Given this list of marker genes CKS2, GREM1, KIF21B, EPC1, ITGA4, USE1, ABHD17C, GCM1, NPTXR, PDLIM5, RAI14, PALS1, ACSL1, DLK2, SPSB4, CRYGD, NOCT, SCAND1 (SCAN domain containing 1), NR1D1, GPR37L1, LTBP3, TRAF1, NFKBIB, KLK8, SRY, TADA3, FBRS, NENF, FHL3, CRK, CTLA4, IL20 (interleukin 20), YIPF3, PLCL2, KCNJ1, IER5, ARHGEF3, IGSF9, ISG15 (NCBI Gene Id 9636), FABP4, RPLP0, NT5C3B, SGCG, MTMR14, MTREX, ZSWIM9, DAPP1, ATF5, ZBTB16, PRNP (prion protein (Kanno blood group)), EVL, SPTAN1, CAPN2, TGM2, AEBP2, GIMAP1, UBE2O, CD7, KRT33B, SLC7A2, FAM133B, PELI2, FABP6, IFT81, SLC44A3, ADM, RGS9, TNFSF9 (TNF superfamily member 9), SNRPB2, KCTD10, PARK7, SDSL, SMARCE1, CDK18 (cyclin dependent kinase 18), SULT1E1, GDAP1L1, GRID2, CCL22, REL, MS4A3, ARG2 (arginase 2), AMMECR1L, PHF13, INAVA, SDF2L1, NIBAN1, OR52A1, TNF, LCP2, RABGEF1, ANXA8 (annexin A8), NTMT1, DDAH2, DEGS2 (delta 4-desaturase, sphingolipid 2), GPBP1, ZNRF1, RSPRY1, LNX2, LTA, CDKN1A, LAMA5 (NCBI Gene Id 3911), ID1, POLD1, RPS27, UQCC2, RAB32, SYN3, SLC3A2, EIF1, PTCH2, KRT5, GPR85 (NCBI Gene Id 54329), GALNT16, FABP3, GADD45B, PRELID1, RTP3, MRPL13, CCT5, KRT85, KIF20A, PPP1R15B, EPHB4 (EPH receptor B4), SLC25A20, P2RY14, PEX7, GRHL1, FGF22, ZNF296, COL9A1, CDK2AP1, HILPDA, ICAM1, GNL3, CNNM3, HAO2, VPREB3, MYBPH, LHX2 (LIM homeobox 2), CDC42EP4, TECTB, ETFDH, ELOC (NCBI Gene Id 6921), THRSP, RFX3, AMPD3, VANGL2, NEK2, GLA, ICOSLG, MYEF2, CA13, MECR, LHX5, BLMH, DUOXA1, EPHA4, HTR3B, NUP62, DTX2, GUCY1A1, SIAH2, ACTRT1, ZNF830, GLRX3, GLRA3, SPIC, RELA, INHA, OPN1SW (NCBI Gene Id 611), PLA2G6, AVP, SATB2, SERPINB5, B3GNT2, MVD, POLA2, DNAJB4, TMEM115, TMEM191C, MT2A, CABP7, RAB34, S1PR3, TBC1D10A, OSBPL6, RBM4, EPPIN, IL1RAP, SH3BP4, MUC13, ANGPTL7, ALPG, CPSF3, PTTG1IP, MAN1A1, PRICKLE1, C8orf82, ACTL7B, SLC25A53, here is a description of the gene set: Human Gene Set: GSE17721_CPG_VS_GARDIQUIMOD_2H_BMDC_UP from publication Amit I, Garber M, Chevrier N, Leite AP, Donner Y, Eisenhaure T, Guttman M, Grenier JK, Li W, Zuk O, Schubert LA, Birditt B, Shay T, Goren A, Zhang X, Smith Z, Deering R, McDonald RC, Cabili M, Bernstein BE, Rinn JL, Meissner A, Root DE, Hacohen N, Regev A (PMID 19729616) species: Homo sapiens mouse primary BMDCs were stimulated with tlr ligands and gene expression changes were profiled on Affymetrix arrays Genes up-regulated in comparison of dendritic cells (DC) stimulated with CpG DNA (TLR9 agonist) at 2 h versus DC cells stimulated with Gardiquimod (TLR7 agonist) at 2 h.